Given this list of marker genes Gxylt1, Wac, Nefh, Phf21a, Ddx6, Rab8b, Daam1, Ipo5, Pcdh10, Ints6l, Eri1, Dcaf7, Cnih4, Ky, Snn, Rrp15, Ube2q2 (ubiquitin-conjugating enzyme E2Q family member 2), Hoxa5, Efcab2, Akap4, Nnmt, Plag1, Hif1a, Plk2, Zfpm2, Slamf9, Hfm1, Peg10 (paternally expressed 10), Fam3c, Slc4a7, H3f5, Nectin4, Mex3b, Pnisr, Fgf10, Atp2b1, Tmem97, Slc19a2, Dcun1d3, Iqschfp, Tnfrsf19, Clic4, Gmnc, Prkar2a, Plcl1, Stox2, Gcnt7, Mapre1, Map3k2, Stau1, Tet2, Slc1a2, Nkain2, Kalrn, Trp53bp2, here is a description of the gene set: Mouse Gene Set: MIR_7038_3P Genes predicted to be targets of miRBase v22 microRNA mmu_miR_7038_3p in miRDB v6.0 with MirTarget v4 prediction scores > 80 (high confidence targets). from publication Chen Y, Wang X (PMID 31504780) species: Mus musculus